The following is a description of a gene set: Genes up-regulated in bone marrow-derived macrophage (45 min): LPS versus IL6 and LPS. from publication El Kasmi KC, Holst J, Coffre M, Mielke L, de Pauw A, Lhocine N, Smith AM, Rutschman R, Kaushal D, Shen Y, Suda T, Donnelly RP, Myers MG Jr, Alexander W, Vignali DA, Watowich SS, Ernst M, Hilton DJ, Murray PJ (PMID 17114459) IL-10 or IL-6 stimulation of control 129xC57BL/6 murine bone marrow derived macrophages in the presence of LPS. We used microarrays to detail the global programme of gene expression changes in response to IL-6 or IL-10 stimulation in the presence of lipopolysaccharide. BMDMs were isolated from control, IL-6-/-, and IL-10-/- mice on a 129XBL/6 mixed background mice and differentiated in the presence of CSF-1 for 6-7 days. Cells were scraped and plated in 6 well plates at 2x10e6/well. Cells were washed with complete DMEM and rested for 1-2 hr before stimulation with combinations of IL-10 (10 ng/ml), IL-6 (2 ng/ml) or LPS (100 ng/ml) for 45 min or 180 mins. Complete biological replicates were performed. Human Gene Set: GSE5589_LPS_VS_LPS_AND_IL6_STIM_MACROPHAGE_45MIN_UP species: Homo sapiens, and this is the list of marker genes: FHIT, HAGHL, UAP1, NIPSNAP1, ZFAND4, HPS4, ZC3H4, TMEM170B, KIAA0513, VAMP3, G6PD, C1QC, NEURL1B, CALHM6, AFTPH, CENPJ, PDE7B, KLF6, PPP3CB, RMND5B, GSTM3, CFAP126, CERS4, FOSB, BANK1 (B cell scaffold protein with ankyrin repeats 1), ZZEF1, TMEM9, KLHL6, PARP8, SERHL2, PNPLA7, TMEM154, PLAU (plasminogen activator, urokinase), STX2, MSRB2, CTTNBP2NL, PAFAH1B3, DCTPP1, TRIM21, PKIG, UPF2, DENND5A, CTSA, FBXW4, KIF9, GLCCI1, GBP7, YPEL3, CPLANE1, MAP3K5, RTTN, RPS27L, GRB2, SURF4, CTDSPL, TWF2, ERLIN1, EPB41L3, MRPS18C, FXR1, DPY19L1, RNF135, CBX7, ING1, RAP1GDS1, GLTP, MARF1, ADCY9, IFT140, EWSR1, ESR1, ZMYND15, AGRN, FMO5, MFSD11, CD82, SLC25A45, CKLF, ALDH5A1, SORD, CYRIB (CYFIP related Rac1 interactor B), ZMAT2, ANAPC15, C12orf57, PIK3R6, SCARB1, POLA1, MOB3A, TOMM7, VPS37C, MTMR14, CIBAR1, EEIG2, P2RY6, SIDT2, H1-0, CDKN2D, FXYD5, ZCCHC8, RAB32, RANBP10, FKBP1B (FKBP prolyl isomerase 1B), CYSLTR1, NEMF, SCAMP1, WDR81 (NCBI Gene Id 780925), ATXN1, NONO, SLC11A1, ASPSCR1, MAGED1, MTR, PTOV1, AP1S2, SAMSN1, RAB42, CXCL16, MON2, LMLN, ASAP1, NHLRC2, E2F8, STARD9 (StAR related lipid transfer domain containing 9), TLE6, TFE3, RASA4, EEF1AKMT1, FUT11, SQOR, CCM2, KDM3B, XPC, AREL1, TPD52, PIK3CG, GAB3, KCTD12, GMNN, CRYBA4, LAMP1, TEF, C1QA, RHBDD3, THBS1, MED22, CDK16, HSDL1, ABTB1, RPL18A, ZXDC, GABARAP, GPR160, ALDH2, USP34, TRIM34, BCAS3, NFAT5, RP9, RELL2, VPS26C, MOB2, CXCL10, SBF2, PHF14, IFIT1, EIF4B, MRPL3, TESK2, DYRK2, VASP, UBE3B, SPATA13, ANAPC5, BOD1L1, SNRPA1, WBP1, H2AJ, MLF2, CD5L, CD86, FOLR2, TOP1, NFATC2, ZNF251, SETD1B, CD93, FCGR2A, DEPTOR, KEAP1, CFAP410, OGFRL1, DDX6, KIF3C, PRDX4 (NCBI Gene Id 82852), LSP1, DOCK1, RAB13, RNF7, PDXK, CSNK1E